The following is a description of a gene set: Human Gene Set: HP_VISUALLY_INDUCED_SEIZURE Visually-induced seizure Seizures evoked by visual stimuli. This includes clinical seizures induced by strobe lighting, television and other screens, flickering environmental lighting and self-induction by causing a strobe effect. species: Homo sapiens, and this is the list of marker genes: SCN2A, EFHC1, CHD2, JRK, GABRD, CPA6, CILK1, SCN1B, CACNB4, SCN1A, CLCN2, SLC9A6, GABRG2, PCDH19, SCN9A, GABRA1, KCNQ3, KCTD7